Given this list of marker genes MAFG, NCOA3, FOXO1, PCNA, SMAD4, NPAS2, CREB1, CLOCK, FBL, DDX21, ALX1, CREBBP, IRF2, POLR1E, BMAL1, here is a description of the gene set: studied in species Homo sapiens Human Gene Set: WP_RUBINSTEINTAYBI_SYNDROME_1 Rubinstein-Taybi syndrome 1